Given this list of marker genes Cul2, Zfp420, Becn1 (NCBI Gene Id 56208), Bnc2, Sox9, Rimbp2, Znrf1, Trip12, Rabgap1l, Nanos1, Gm4871, Dolpp1, Arhgef6, Mzt1, Elovl5, Zfp644, Nadk, Ccnjl, Ell2, Dll4, Pgm1, Sema6d, Setd7, Lhx8, Sos1, Tdg, Fkbp3, Oxr1, Htr4, Trappc14, Ubn1, Chl1 (cell adhesion molecule L1-like), Celf4, Cbfb, Klf8, Desi2, Tecrl, Ccdc43, Rnf157, Khnyn, B4galt6, Mat2a, Slc38a7, Unc5c, Pip4k2a, Gigyf2, Ntng1, Map3k2, Plch1, Fam13c, Kmt2c, Slc36a1, Msi2, Pou3f4, Nfat5, Adamts3, Trpm7, Rps6ka2, Rgs8, Col13a1, Spcs3, Azin1, Rundc3b, Baz2b, Tasp1, Smap1, Cadm2 (cell adhesion molecule 2), Sec23a, Edem3, Mical1, Scn2a (NCBI Gene Id 241424), Dennd2c, Dlgap4, Ube2i, Cep170, Lin28b, Terb2, Mfsd6 (NCBI Gene Id 98682), Ark2c, Fam91a1, Skp2, Ypel5, Rap1b, Asah1, Herc6, Foxb1, Tbl1xr1, Washc4, Psmd7, Lonrf1, Zcchc2, Bnip3l, Man1a2, Impact, Itpk1, Siah2, Katnbl1, Ino80d, Crkl, Mttp, C9orf72, Jdp2, Gatm, Ppp4r4, Fndc3a, Sirt1, Gpcpd1, Gna13, Camk2d, Scara5, Rab2b, Dnajc13 (NCBI Gene Id 546159), Glcci1, Lgi1, Vat1, Lrfn2, Prickle1, Proser1, Rad23b, Wwtr1, Ttbk1, Brd10, Ednra, Amotl2, Nr6a1, Det1, Spast, Tbc1d30, Ubn2, Shoc2, Klhl20, Cnot6, Pax3, Zbtb18, Cblb, Twf1, Tenm3, Sh3rf1, Phtf2, Ascc3, Tle1, Pptc7, Mbtps2, Chst1, Zfp608, Reep1, Hectd2, Slc35f4, Mdm4, Slc15a2, Col9a3, Zfp36l2, Atp6v0d1, Ppp3cb, Atp2b2, Sec24d, Dcun1d1, Dgkz, Tepsin, Scn1a, Fzd3, Nhlh2, Pdlim5, Setd5, Kcna4, Mier3, Nfatc3, Usp47, Efna3, Rapgef2, Mfap5, Nap1l5, Calcr, Zdhhc17, Serpine1, Irf4, Adamts6, Adgra3, Epc2, Myo5a, Cep350, Scn3a, Syngr3, Tbc1d10b, Mlxip, Slc38a4, Jarid2, Haus4, Galr1, Bdp1, Map3k13, Yaf2, Usp45, Gnai2, Kif5b, Plppr4, Ankra2, Cdca7, Pfn2, Cthrc1, Mkrn3, Rbm44, Tmem121, Runx2, Hic2, Necap1, Ap3s1, Pank3, Zfp770, Vip, Prdm1 (PR domain containing 1, with ZNF domain), Cracdl, Dcbld1, Nedd4, Itgbl1, Map3k5, Xpo1, Tet1, Ncam1 (neural cell adhesion molecule 1), Rhebl1, Camk2n1 (calcium/calmodulin-dependent protein kinase II inhibitor 1), Wdr7, Rnf220, R3hdm1, Coq3, Terf1, Sptssb, Map3k12, Atxn1, B3gnt5, Usp2, Gabrb1, Ypel2, Lamp3, Zbtb34, Hdac9 (histone deacetylase 9), Dpy19l1, Galnt2, Eml1 (echinoderm microtubule associated protein like 1), Mast4, Cyb561, Limch1, Slc35c1, Sall4, Per2, Srgap3, Ppp1r12a, Scn9a, Psd3, Stac, Cep170b, Rfx6, Vkorc1l1, Rfx7, Plagl2, Ddx19b, Lrch2, Brd1, Srsf7, Omg, Pcgf5, Ip6k3, Fbxo42, Dsg2, Snx18, Wipf3 (NCBI Gene Id 330319), Cpne8, Xpr1, Lin7c, Celsr3, Ifi213, Ssh2, Meox2, Gzf1, Wdr82, Ppp3ca, Arid5b, Ptpn13, Mab21l1, Rps6ka5, Zmynd8, Prps1l3, Ddah1, Smad1, Ssx2ip, Fosl2, Ado, Ube3c, Etaa1, Reep3, Nus1, Actc1, Lin28a, Ccdc71l, Rbm46, Abcc9, Gpt2, Fbln5, Gpr180, Spen, Myh11, Oga, Slc35f3, Zfp521, Ppp2r1b, Tfdp1, Foxd1, Stox2, Acvr1, Gnai1, Grm3, Fst, Edn2, Erg, Ankhd1, Evx2, Kdm3a, Samd8, Dpysl2, Atg12, Slc30a4, Cysltr1, Elavl2 (NCBI Gene Id 15569), Mitd1, Socs1, Gjc2, Mybl2, Sh3pxd2a, Itga8, Ccnk, Map3k21, Six4, Kcnmb2, Ppargc1a, Stxbp5, Nhsl3, Strip1, Slc7a10, Pcdh17, Tnxb, Atg3, Lmbr1l, Sema3a, Lpar3, Afap1l2, Septin8, Ide, Plxna1, Mboat1, Il21r (interleukin 21 receptor), Larp4, Ric3, Usp48, Mmd, Hbs1l, Ano4, Asb3, Dact1, Adra1d, Dcun1d3, Sh2b3, Maml1, Cilk1, Sec24a, Tmeff1 (NCBI Gene Id 58247), Ap4e1, Tmem181a, Mier2, Camta1, Tcp11l2, Samd4, Gtf2h4 (general transcription factor II H, polypeptide 4), Erich5, Ccnt2, Ythdf3, Nrg3 (NCBI Gene Id 18183), Kctd8, Tnrc6a (trinucleotide repeat containing 6a), Snai1, Lrrc40, Capn7, Snx33, Tulp4, Vopp1, Fnip2, Sypl1, Tcfl5, Atp6v1c1, Lrrk2, Bnc1, Ptp4a1, Ccne2, Nlgn1, Actr1a, Fign, Galnt1, Wipf1, Exoc6, Rab32, Mfsd11, Ndel1, Ankrd17, Macroh2a1, Capn5, Mafg (v-maf musculoaponeurotic fibrosarcoma oncogene family, protein G (avian)), Pik3cd, Slc35a3, Extl2, Tnrc6c, Slc41a2, Dlg5, Tcaf3, Fam199x, Gper1, Naaladl2, Lrp6, Cand1, Lclat1, Pcnx2, Nsg1, Stk35, Calu, Slc4a7, Chka (choline kinase alpha), Ywhaz, Cth, Arid1a, Nrxn3, Pon2, Pde7a, Zdhhc20, Rai14, Lifr, Kras, Slc7a6 (NCBI Gene Id 330836), Nedd4l, Plxnc1, Mcf2l, Apaf1, Atosa, Vmn1r71, Taok1, Lox, Fam83f, Elmod2, Cep41, Brwd3, Ppp3r1, Prlr, Sema6b, Jph4, Ccn4, Csnk1a1, Slc35d3, Tia1, Usp37, Ptpn2, Gria2, Ccdc6, Bahd1, Eed (NCBI Gene Id 16759), Cdc37l1, Pawr, Ppid, Rgs17, Stim2, Trp53inp1, Chd7 (NCBI Gene Id 57137), Rora, Epb41, Nabp1, Epb41l3, Papola, Dock7, Ppp1r18, Map6, Runx1, Cyp24a1, Ptpn21, Eif5a2, Frmpd1, Gja1, Sgk3, Dsc2, Adam9, Neurl1b, Bcl2l11, Garre1, Zdhhc21, Ago3, Esyt3, Cdh20 (NCBI Gene Id 23836), Stag2, Gmeb1, Abcd2, Foxg1 (NCBI Gene Id 73022), Apba1, Cfap61, Zfp560, A630023A22Rik, Aox2, Zbtb41, Xkr4, Jade3, Ttll7, Cnot9, Dlgap2, Tmem200a, Gldc, Lipi (lipase, member I), Cpsf6, Frzb, Ptgfrn, Six1, Fbxo32, Scn8a (NCBI Gene Id 637355), Clock, Lrrc17, Stx2, Tbc1d15, Ube2v2, Tmem170b, Kctd7, Rasa1, Rap2c, Klf10, Rasd1, Glce, Stk39, Csnk1g1, Dio2, Snrpn, Edc3, Sel1l3, Atp2a2, Rarg, Lpp, Ube2j1, Mex3b, Zfp518a, Myo9b, Itgb3, Nefl, Esco1 (establishment of sister chromatid cohesion N-acetyltransferase 1), Large1, Dgkq, Septin7, Nr5a2, Nrk (NCBI Gene Id 27206), Jakmip2, Capza1, Irx4, Polr3g, Tab3, Adra2a, Cadps, Nagpa, Slc38a2, Vim, Hycc2, Carf, Rasgef1a, Gli2, Ppp1r1c, Scel, Lpgat1, Klf9, Sp4, Nf1, Sdad1, Snapin, 0610040J01Rik, Tnrc6b, Apbb2, Pdcd5, Snx16, Dnmt3a, Nt5e, St8sia4, Vat1l, Rab38, Cop1, Ercc6l2, Tmem87a, Pdss1, Usp50, Picalm, Galnt3, Arid4a, Gmeb2, Zfp507, Ago1, Hecw1, Pbrm1, Sgcb, Mbnl3, Polr3e, Cnr1, Slc35f1, Erlin1, Fam43a, Fbxo45, Ppargc1b, Exo5, Bmp5, Cacnb2 (NCBI Gene Id 99300), Flvcr1, Ankrd55, Elavl4, 4933409G03Rik, Eml4 (NCBI Gene Id 78798), Camkk2, Slc12a6, Pip4k2b, Plekho2, Ddit4, Rasa2, Zcchc24, E2f7, Rassf10, Rab23, Pnkd, Lcorl, Piezo2, Rab15, Chst2 (carbohydrate sulfotransferase 2), Fhip2a, Rrad, Galnt7, Tent2, Ifngr1, Ror1, Rnf122, Itfg1, Rimklb, Avl9, Mtdh, Chd1, Rapgef4, Adam19, Plekhm3, Socs3, Phactr2 (NCBI Gene Id 215789), Sytl4, Tent5a, Hnrnpul2, Tmod2, Hycc1, Prkaa2, Cfl2, Ap1s2, Bcor, Irs1, Marchf4, Gabra5, Osbpl8, Tcstv2c, here is a description of the gene set: Mouse Gene Set: MIR_30B_5P_MIR_30C_5P studied in species Mus musculus Genes predicted to be targets of miRBase v22 microRNA mmu_miR_30b_5p, mmu_miR_30c_5p in miRDB v6.0 with MirTarget v4 prediction scores > 80 (high confidence targets). from publication Chen Y, Wang X (PMID 31504780)